The following is a description of a gene set: species: Homo sapiens Human Gene Set: GOBP_EPITHELIAL_CELL_PROLIFERATION_INVOLVED_IN_RENAL_TUBULE_MORPHOGENESIS Any epithelial cell proliferation that is involved in renal tubule morphogenesis., and this is the list of marker genes: C1orf54, MTSS1, MEF2C, LGR5 (leucine rich repeat containing G protein-coupled receptor 5), LGR4